The following is a description of a gene set: species: Mus musculus Genes positively differentially expressed in cell type: γδ T cell upon treatment with cytokine: TGF-β1 in mouse lymph nodes in vivo. from publication Cui A, Huang T, Li S, Ma A, Pérez JL, Sander C, Keskin DB, Wu CJ, Fraenkel E, Hacohen N (PMID 38057668) Cytokines mediate cell-cell communication in the immune system and represent important therapeutic targets. A myriad of studies have highlighted their central role in immune function, yet we lack a global view of the cellular responses of each immune cell type to each cytokine. To address this gap, the authors created the Immune Dictionary, a compendium of single-cell transcriptomic profiles of more than 17 immune cell types in response to each of 86 cytokines (>1,400 cytokine-cell type combinations) in mouse lymph nodes in vivo. A cytokine-centric view of the dictionary revealed that most cytokines induce highly cell-type-specific responses. For example, the inflammatory cytokine interleukin-1β induces distinct gene programmes in almost every cell type. A cell-type-centric view of the dictionary identified more than 66 cytokine-driven cellular polarization states across immune cell types, including previously uncharacterized states such as an interleukin-18-induced polyfunctional natural killer cell state. Mouse Gene Set: CUI_T_CELL_GD_TGF_BETA_1_RESPONSE_UP, and this is the list of marker genes: Qpct, Itgae, Znrf1, Rgs10, Ctsw, Cd52, Krt83, Retreg1, Pmepa1, Ypel3, Aqp3